The following is a description of a gene set: Human Gene Set: REACTOME_RESPONSE_TO_ELEVATED_PLATELET_CYTOSOLIC_CA2 Response to elevated platelet cytosolic Ca2+ studied in species Homo sapiens, and this is the list of marker genes: PRKCG, HSPA5, WDR1, SELP, IGF2, PCYOX1L (NCBI Gene Id 78991), A2M, ABCC4, VEGFB, TIMP3, PDGFB, CYB5R1, ORM1, SERPINE1, PDGFA, PRKCB, PPIA, FERMT3, ITIH3, VCL, PPBP, ACTN4, VEGFA, QSOX1, SRGN, STX4, VTI1B, NHLRC2, THBS1, FGA, PECAM1, TF, FAM3C, PCDH7, MAGED2, LHFPL2, HABP4, APP, F8 (NCBI Gene Id 14069), FLNA, CTSW, ECM1, ITIH4, CALU, PHACTR2, IGF1, CDC37L1 (cell division cycle 37 like 1, HSP90 cochaperone), GTPBP2, TIMP1, VEGFC, SERPINA4, ORM2, FGG, MANF, CAP1 (cyclase associated actin cytoskeleton regulatory protein 1), PF4, PLEK, CFD, TLN1, LEFTY2, TMSB4X, VWF, APOH, CD109, TGFB3, CLU, CLEC3B, ANXA5, TGFB1, SYTL4, AHSG, ALB, SERPINA1 (serpin family A member 1), TTN, LGALS3BP, SERPINA3, MMRN1, PROS1, ACTN2, A1BG, CD36, ENDOD1, APOOL, HGF, TAGLN2, ITGA2B, ALDOA, ITGB3, CYRIB, RARRES2, CHID1, GAS6, APLP2, PLG, PSAP, SCG3, F13A1, STXBP3, F5, HRG, EGF, LY6G6F (NCBI Gene Id 259215), ISLR, TGFB2, CD9, CFL1, TMX3, PFN1, APOA1, SOD1, SPP2, FGB, TOR4A, FN1, SELENOP, OLA1, SPARC, SCCPDH, SERPINF2, TEX264, TUBA4A, VEGFD, BRPF3, STXBP2, ACTN1, CALM1, KNG1, LAMP2, PRKCA, SERPING1, CD63, RAB27B